Given this list of marker genes Slc4a2, Runx3, Cbfb, Runx1, Lilrb4a, Socs1, Nckap1l, Zbtb7b, Lilrb4b, here is a description of the gene set: studied in species Mus musculus Any process that modulates the frequency, rate, or extent of CD8-positive, alpha-beta T cell differentiation. Mouse Gene Set: GOBP_REGULATION_OF_CD8_POSITIVE_ALPHA_BETA_T_CELL_DIFFERENTIATION